Given this list of marker genes TBX2, HAS2, GATA6, GATA4, PTPN11, TBX20, ENG, RBPJ, SMAD4, FOXN4, CHD7, TBX3 (T-box transcription factor 3), BMP2, here is a description of the gene set: Human Gene Set: GOBP_ATRIOVENTRICULAR_CANAL_DEVELOPMENT The progression of the atrioventricular canal over time, from its formation to the mature structure. The atrioventricular canal is the part of the heart connecting the atrium to the cardiac ventricle. studied in species Homo sapiens